The following is a description of a gene set: studied in species Mus musculus Mouse Gene Set: MIR_6904_3P from publication Chen Y, Wang X (PMID 31504780) Genes predicted to be targets of miRBase v22 microRNA mmu_miR_6904_3p in miRDB v6.0 with MirTarget v4 prediction scores > 80 (high confidence targets)., and this is the list of marker genes: Baz2b, Fam199x, H2bc24, Slc50a1, Onecut2, Fmn1, Clec14a, Klf11, Pex5, Fut9, Aqp4, Angptl3, Dcaf5, Txlng, Plscr1, Rock1, Mmd, Csnk1g1, Man1a, Herc6, Pip5k1b, Ccng2, Fam168a, Itgb8, Ncoa2, Plpp6, Errfi1, Pcdhb9, Ankrd29, Kctd12, Ankhd1, Cngb1, Tanc2, Zfp397, Skp1, Dnajc25, Txnl4a, Cd244a, Hoxc13, Stau2, Papola, Smarce1, Ier3ip1, Slc6a20b (solute carrier family 6 (neurotransmitter transporter), member 20B), Saxo2, Septin11, Gemin6, H2bc23, Otud5, Omd, Prpf39, Or51ab3, Fhl4, Pck1, Cdc14a, Zfp148, Tmed5, Desi2